Given this list of marker genes WDR54, FABP6, MORN2, DYNLT4, NQO1, PSENEN, GSTA2, CD59, PSCA, DYNLL1, C11orf97, CYSTM1, DNAAF1, FAM216B, CFAP90 (NCBI Gene Id 134121), KIF21A, DYNLT2B, C12orf75, CAPSL (NCBI Gene Id 133690), TMC5, FXYD3 (FXYD domain containing ion transport regulator 3), IFT25, TXN, RSPH1, AGR3, DYNLRB2, ZMYND10, MORN5, IK, ATP5IF1, ROPN1L, CAPS, TFF3, CDS1, SPAG16, DNPH1, TUBB4B (NCBI Gene Id 10383), POLR2I, LRRC46, TSTD1, HOATZ, MUC5AC, GSTA1, DNAH5, ALDH3A1, FAM81B, SPA17, LRRC10B, CKB, TSPAN19, GDF15, HSBP1, MRPS31, PRDX5, WDR38, CIBAR2, TMEM190, CETN2, DHRS9, SCGB2A1, CCDC80, CIMAP3, ECRG4, SPMIP6, CRNDE, LRRIQ1, CFAP53, PPIL6, LRRC23, CRIP1, ANKUB1, KIF9, PIERCE1, HMGN3, IQCG, CFAP144, RRAD, FAM174A, FOXJ1, PLAC8, FAM229B, DRC1, LDLRAD1, CCDC74A, TUBA4B, TSPAN1, PROM1, MNS1, AKAP14, CCDC78, TSPAN6, CFAP95, CLXN, CCDC146, CES1, CFAP73, SNTN, CFAP126, B9D1, UFC1, IFT172, SLC44A4, ERICH3, BASP1, DNAAF4, CFAP300, TUBA1A, CDHR3, CFAP276, EPPIN (epididymal peptidase inhibitor), CFAP210, DMKN, CIMIP1, ALDH1A1, DRC12, CHST9, CD24, ALDH3B1, DPCD, CCDC17 (coiled-coil domain containing 17), FANK1 (fibronectin type III and ankyrin repeat domains 1), CYP4B1, NME5, MLF1, RSPH4A, LINC01571, ADH7, EFHC1, DRC3, EZR, ARL3, TEKT1, DPY30, ELF3, OMG (NCBI Gene Id 4974), CFAP298, DYNLT1, SPAG6, SMIM22, CCDC170, NUCB2, SAXO2, IFT57, TPPP3, CIMAP1B, CABCOCO1, CFAP45, CCDC190, IGFBP2, DNALI1, RSPH9 (radial spoke head component 9, NCBI Gene Id 221421), CFAP251, PRDX1, NUDC, CIB1, here is a description of the gene set: Human Gene Set: DURANTE_ADULT_OLFACTORY_NEUROEPITHELIUM_RESPIRATORY_CILIATED_CELLS from publication Durante MA, Kurtenbach S, Sargi ZB, Harbour JW, Choi R, Kurtenbach S, Goss GM, Matsunami H, Goldstein BJ (PMID 32066986) species: Homo sapiens